Given this list of marker genes ACADS, EHHADH, ACSF2, ECI1, SCP2 (sterol carrier protein 2), PECR, ACSL3, ACADVL, ACSL1, ACADM, ACADL, HADH, SLC25A20, CPT2, HADHA, ACSL4, CPT1A, here is a description of the gene set: Human Gene Set: WP_MITOCHONDRIAL_LONG_CHAIN_FATTY_ACID_BETAOXIDATION Mitochondrial long chain fatty acid beta-oxidation studied in species Homo sapiens